Given this list of marker genes Ppara, Il10, Ptx3 (pentraxin related gene), Mtor, Clu, Hsp90ab1, Insr, Ifng, App, Cd47, Slc7a2, Ptgis, Crp, Nos2, Thap4, Agt, Cx3cr1, Agxt2, Cps1, Rora, Akt1, Jak2, Ulbp1, Asl, Nfatc3, Pkd2, Gimap3, Klf4, Epor, Ticam1, Oprm1, Nosip, Igf1, Rock2, Tlr6, Clec7a, Cyb5b, Mtarc2 (mitochondrial amidoxime reducing component 2), Acvr2a, Itgb2l, Slc7a6, Sod2, Rac1, Apoe, Por, Rgn, Khsrp, Hsp90aa1, Cyp1b1, Selenos, Tlr4, Tlr2, Nos3, Il1b, Il4, Gimap5, Tnf, Esr1, Cyp1a1, Hrh1, Mtarc1, Smpd3, Ptgs2, Cyb5r3, Spr, Gla, Cd36, Mapk9, Atp2b4, Akt2 (NCBI Gene Id 76480), Klrk1, P2rx4, Raet1d, Prdx5, Npy, H2-M3, Tmem106a, Sirpa, Zc3h12a, Cav1, Tspo, Dynll1, Wdr35, Klf2, Aif1, Itgb2, Dnm2, Icam1, Nos1, Cygb, Ass1, Ptk2b, Ddah1, Acp5, Smad3, Pik3cb, Il6, Tlr5 (toll-like receptor 5), Trpv1, here is a description of the gene set: The chemical reactions and pathways involving a reactive nitrogen species. Mouse Gene Set: GOBP_REACTIVE_NITROGEN_SPECIES_METABOLIC_PROCESS studied in species Mus musculus